The following is a description of a gene set: The appearance of interleukin-1 beta due to biosynthesis or secretion following a cellular stimulus, resulting in an increase in its intracellular or extracellular levels. Mouse Gene Set: GOBP_INTERLEUKIN_1_BETA_PRODUCTION studied in species Mus musculus, and this is the list of marker genes: Ghsr, Gstp2, Gsdmd, Foxp1, Ffar4, Il1b, Mndal, Lilra5, Gstp1, Wnt5a, Aim2, Ifi214, F2r, Ccr5, Lpl, Ifi209, Hspb1, Trem2, Sirpa, Hmgb1, Smad3, Lilrb4a, Gbp5, Cx3cr1, Ifi206, Ccl19, Aqp4, Cptp, Naip5, Nod2, Casp8, Tlr6 (toll-like receptor 6), Il17a, S1pr3, Tnfaip3, Ager, Tyrobp, Tlr8 (NCBI Gene Id 170744), Ccn1 (cellular communication network factor 1), Jak2, Chrna7, Rad21, Nlrp6, Nlrc4, F2rl1, Isl1, Tlr2, Gstp3, Stmp1, Cd36, Ripk2, Ifi207, Ffar1, Errfi1, Rela, Myd88 (NCBI Gene Id 17874), Eif2ak3, Egr1, Ghrl, Ifi203-ps, Arrb2, Lilrb4b, Fzd5, Acp5, Nlrc3, App, Apoa1, Tnfaip8, Casp1, Clec7a, Tlr4, Ccl3, Malt1, Elf4, Nlrp3 (NLR family, pyrin domain containing 3), Ifi203, Pml, Ccr7, Gstp-ps, Igf1, Gorasp2, Mefv, Spag11a, Il6, Git1, Gsdma3, Sphk1, P2rx7, Stat3, Hk1, Nlrp1a (NLR family, pyrin domain containing 1A), Pycard, Serpinb1b, Ifi208, Ifnar1, Serpinb1a (NCBI Gene Id 66222), Arg2, Usp50, Inava, Casp4, Nlrp1b, Nod1, Zc3h12a, Ifng, Panx1, Sucnr1, Tnf, Slamf9, Serpinb1c, Ifi213, Ern1, Mr1, Tmem106a